The following is a description of a gene set: studied in species Mus musculus Combining with any modified low-density lipoprotein (LDL) or other polyanionic ligand and delivering the ligand into the cell via endocytosis. Ligands include acetylated and oxidized LDL, Gram-positive and Gram-negative bacteria, apoptotic cells, amyloid-beta fibrils, and advanced glycation end products (AGEs). Mouse Gene Set: GOMF_SCAVENGER_RECEPTOR_ACTIVITY, and this is the list of marker genes: Ackr4, Scarb2, Enpp2, Megf10, Ackr2, Colec12, Stab1, Enpp1, Megf11, Ssc5d, Ackr3, Endou, Stab2, Prg4, Scarf1, Cxcl16, Cd163, Scarb1, Dmbt1, Lgals3bp, Scarf2, Megf6, Cd36, Msr1, Vtn